The following is a description of a gene set: from publication Chen Y, Wang X (PMID 31504780) Genes predicted to be targets of miRBase v22 microRNA hsa-miR-518d-5p, hsa-miR-518f-5p, hsa-miR-520c-5p, hsa-miR-526a-5p in miRDB v6.0 with MirTarget v4 prediction scores > 80 (high confidence targets). species: Homo sapiens Human Gene Set: MIR518D_5P_MIR518F_5P_MIR520C_5P_MIR526A_5P, and this is the list of marker genes: FLT3, EWSR1, C6orf136, GHSR, FAM174B, CNNM3, SCNN1B, NCEH1, PLGLB1, ARL2BP, RBM27, MSH5, ZCCHC10, DLL3, ZNF823, NFIA, NR3C1, TMEM87A, TBR1, CCDC91, SEMA6A, HMGN1, RB1CC1, KLF15, GIPC3, TMEM170B, LSM8, HMGB3, OSBPL6, KCNJ14, HIPK1, NCOA2, AMZ2, JPH4, TRIOBP, RANBP2, USP8, CNTLN, PTPN21, NRCAM, CLK4, G3BP1, GALNT11 (NCBI Gene Id 63917), SFT2D3, ZSWIM6, KCNIP2, CREBRF, ADGRB3, LPGAT1, SIKE1, SLC25A33, TRIM10, TXNRD2, COX20, HOXB9, CHORDC1, BEND4, DNM3, ACSM3, PTGES3L, NXPE3, NMT2, LHFPL5, DCAF10, RELL1, TMEM65, ECHDC1, HYKK, FLI1, ZNF512, FBXO40, AJUBA, TFRC, SS18, EGLN3, SAV1, FGF7 (fibroblast growth factor 7), PPP4R3B, LCP1, LILRA1, ELOVL6, BCL2L2, MED4, NUDT4, PLGLB2, RP1, PRRC1, ZNF45, PRRC2C